Given this list of marker genes SLPI, NR5A2, HMGA2, HACD3, IFNL3 (interferon lambda 3), TNF, TOP2A, IFITM2, BANF1, MX1, APOBEC3D, OAS2, APOBEC3C, DDX3X, BST2, INPP5K, VAPB, FAM111A, N4BP1, TARBP2, BCL2, PLSCR1, CNOT7, IFIT1, SRPK1, GBP7, PABPC1, APOBEC3G, APOBEC3A, ZC3HAV1, EIF2AK2 (NCBI Gene Id 5610), IFIT5, LTF, TRIM28, PPIA, SRPK2, IFNB1, TNIP1, APOBEC3B, IFITM1, ISG20, PPIH, NOTCH1, OAS3, APOBEC3H, APOBEC3F, OAS1, ISG15, DDX5, BTBD17, DDB1, AICDA, CD28, CXCL8, PPIE, OASL, PDE12 (phosphodiesterase 12), STAU1, SHFL, IFIH1, TOP2B, ADARB1, CCL5, TMEM39A, PKN2, FKBP6, ZNFX1, ILF3, RAD23A, RSAD2, TRIM6, IFI16, PROX1, PPID, ADAR, MAVS, TRIM38, LARP1 (La ribonucleoprotein 1, translational regulator), IFITM3, RNASEL, here is a description of the gene set: species: Homo sapiens Any process that modulates the frequency, rate or extent of viral genome replication. Human Gene Set: GOBP_REGULATION_OF_VIRAL_GENOME_REPLICATION